The following is a description of a gene set: Human Gene Set: GOBP_UDP_N_ACETYLGLUCOSAMINE_BIOSYNTHETIC_PROCESS studied in species Homo sapiens The chemical reactions and pathways resulting in the formation of UDP-N-acetylglucosamine, a substance composed of N-acetylglucosamine, a common structural unit of oligosaccharides, in glycosidic linkage with uridine diphosphate., and this is the list of marker genes: GFPT1, GFPT2, AMDHD2, GNPNAT1, PGM3, NAGK, GNPDA1, UAP1 (NCBI Gene Id 6675, UDP-N-acetylglucosamine pyrophosphorylase 1), GNPDA2, UAP1L1